Given this list of marker genes PRDM6, NSD2, TTLL12, SMYD5 (SMYD family member 5), KMT5B, KMT5A, SETD4 (NCBI Gene Id 54093), KMT5C, PRDM9, NSD1, here is a description of the gene set: Human Gene Set: GOMF_HISTONE_H4K20_METHYLTRANSFERASE_ACTIVITY Catalysis of the reaction: S-adenosyl-L-methionine + histone H4 L-lysine (position 20) = S-adenosyl-L-homocysteine + histone H4 N6-methyl-L-lysine (position 20). This reaction is the addition of a methyl group to the lysine residue at position 20 of the histone H4 protein. studied in species Homo sapiens